Given this list of marker genes CDK4, PIK3CB, NFKB2, CUL3, PIK3R1, CDKN2A, CASP8, PDPK1, GAB1, TERT, FAT1, REL (NCBI Gene Id 5966), PIK3R2 (NCBI Gene Id 5296), EIF4E, SESN2, PIK3CA, NOTCH1, PRKAA1, MTOR, FKBP1A, NFE2L2, TP53, AKT3, CCND1, VEGFA, PTEN, RICTOR, MAPKAP1, EIF4EBP1 (NCBI Gene Id 1978), RPS6KB2, TGFBR2, MAML1, TP63, DDIT4, PIK3R5, RPTOR, SESN1, RPS6, HRAS, ERBB2, FGFR1, CTNNB1, NRAS, PIK3CG, NOTCH2 (notch receptor 2), NFKB1, PRKAA2, IGF1R, CDK6, STK11, RELA, CSMD3, BIRC2, AKT1 (AKT serine/threonine kinase 1), E2F1 (E2F transcription factor 1), EGFR, TRAF3, AKT2, CDKN1A, FADD, FGFR2, TSC2, KRAS, KEAP1, RB1, MIRLET7C, RHEB, NUMB, SMAD4, IRF6, TSC1, MLST8, AJUBA, FGFR3, here is a description of the gene set: Human Gene Set: WP_HEAD_AND_NECK_SQUAMOUS_CELL_CARCINOMA species: Homo sapiens Head and neck squamous cell carcinoma